The following is a description of a gene set: species: Homo sapiens Genes down-regulated in Foxp3-ires-GFP T conv (FOXP3-): B6 versus NOD background. Human Gene Set: GSE37605_C57BL6_VS_NOD_FOXP3_IRES_GFP_TCONV_DN from publication Darce J, Rudra D, Li L, Nishio J, Cipolletta D, Rudensky AY, Mathis D, Benoist C (PMID 22579475) The aim of this study was to quantify the impact of chimeric Foxp3-GFP protein on the Treg cell transcriptional program., and this is the list of marker genes: IFT57, GNA13, NCOA5, CLEC2D, RGS14, FCF1, TNFRSF17 (NCBI Gene Id 608), NFKBIL1, KICS2, PSMD7, PLEKHJ1 (pleckstrin homology domain containing J1), TTK, LAPTM4A, PHLPP2, STIM2, LRATD2, CAPG, NAPB, JAKMIP3, TMEM59, APTX, ZFPL1, GEMIN2, PTGS2, NMT1, IRF5, MAPKAPK3, CRCP, PLD4, JAG1, SERPINI1, GPR132, PSTPIP1, HCLS1, LSG1 (NCBI Gene Id 55341), STK38 (NCBI Gene Id 11329), FXYD1, INSL6, TAF15, DUSP10, RINT1, JDP2, KRTDAP, SNX20, SPDL1, MED13, SSTR3, WIPF2, HSD17B6, TAF7L, PTPRO, SLC1A4, H4C14, PPP2R2D, SCYL3, CSRNP1, SESN2, EPHA7, HSD11B2, MOCS2, CDK5RAP1, TCOF1, CSF2RBP1, KMO, BIN3 (NCBI Gene Id 55909), FIS1, SNX17, GNS, ATP6V1B1, ABTB2, PRPF38B, SLC17A8, HOMER1, GNG11, DUSP16, YTHDC1, ARID5A, PLEKHA2 (pleckstrin homology domain containing A2), USP35, HDAC7, VPS33A, TDRD5, MRM3 (NCBI Gene Id 55178), SLC38A7, RFLNB, FREM1, RALA, TYW1, KDM4A, YKT6, REEP3, SNAPC3, TMEM11, SYF2, MS4A1, LARGE2, CCT3, RNF25, NCAM2, HEYL, SZT2, SLC16A3, ARID5B, ENDOD1, USP39, MDM4, MRPL45, FILIP1, ELL2, OSBPL3, ZSWIM2, CYP26B1, VTA1, S1PR2, LTA, AK2, TESMIN, FCGR2B, LUC7L3, BAZ1A, RAB3IP, DNAJA1, BRMS1L, KLHL38, PLK4, NUDT9, MIR665, TJP1, SUMO1, LRTM1 (leucine rich repeats and transmembrane domains 1), DHRS7B, DCAF15, GNL1, FFAR1, UROS, MRPL21, CHAC1, TTC9C (NCBI Gene Id 283237), KMT5A, ESD, ECE2, FAM53C, IGLON5, FGF14, SLC22A3, OPA3, KCNK5, RBM7, AMZ2, CLPTM1, GMFG, POU3F1, EZR, RNF215, TMEM86A, MSN, SERPING1, PACS2, RPL3L, RPS5, SIK3, AMN1